Given this list of marker genes EBF1, SLAIN1, LRRTM3, ARHGEF26, ZNF254, UHRF2, ATP7B, DYRK1A, OSTC, SGIP1, ACKR4, GJC3, CBLL1, ETV3 (NCBI Gene Id 2117), ODR4, FPGT, FXR2, TBC1D23, CAMK4 (calcium/calmodulin dependent protein kinase IV), P2RY1, CHN2, PANK1, INVS, KLC1, MAGEB1, VIRMA, CCDC117, CHUK, VEGFD, AMMECR1, TMEM255A, CAMK2D, ARID4B, FGF5, EGFR, TUBGCP3 (tubulin gamma complex component 3), SGO1, MBNL2, ACVR2A, SYT4, POU2F2, OSBPL6, PDS5A, SLC25A13, BPTF, MAP3K2, CXorf66, CALCR, ANTXR2, MAGOH, HTRA3, TEAD3, USP15, ASXL3, MRI1, SNX9, RGS5, TMEM184A, MALT1, GARIN6, CREB5, FBN2, GOLGA1, DYNC1I1, MS4A3, CISD1 (CDGSH iron sulfur domain 1), PHF19, SPATA9, LY75, REST, USP38, STK17A, COL8A1, OTOGL, CPEB2, GANC, PALM2AKAP2, EMP2, MSR1, PTGER4, ZNF292, ACER3, FOXA2, AKAP7, CSTB, UNC79, PHF6, USP49, SP1, PLCH1, PTER, FSD2, RAB2A, NAALADL2, RIMBP2, KCNAB1, ZDHHC5, MLLT3, USP43, SNAPC5, CAPN2, CRTC1, SRGAP1, VPS45, NIPAL3, ZFP69B, SLC4A7, PPP4R3A, RICTOR, RSBN1L, PIP5K1B, LRRC8C, CERKL, ANKRD13C, ANK2, ANTXR1, COLEC12, APOBEC4, EHHADH, MGME1, BEGAIN, EID1, SCAI, EPCAM, SH2D1A, ITPR2, C11orf54, SORCS1, SCP2 (NCBI Gene Id 6342), SEMA6A, SHISA9, RNGTT, TMEM135, DPT, LRRTM2, SEC23IP, RASGRF2, MMUT, C20orf173, GYS2, NDUFV3 (NADH:ubiquinone oxidoreductase subunit V3), PRKACB, RPL36A, FNDC3A, TGFB2, KLF9 (NCBI Gene Id 687), KDM5A, SMC4, TMEM161B, GALNT15, SDHC, THSD7A, KIF13B, RNF207, PSMC2, IL5RA, RNF144A, ERBB4 (erb-b2 receptor tyrosine kinase 4), KCNK2, RTKN2, PCDH7, C6orf120, SFT2D3, INHBC, CUL4A, ZBTB6, TMEM248, ATF7IP (NCBI Gene Id 55729), GARRE1 (granule associated Rac and RHOG effector 1), ORC5, WNK2, XDH, DLG1, SYNPO2, TMEM39B, TSPO2, OGN, SMTNL1, PLEKHH1, BTG2, SYN2, CNTN6, PREX2, HIGD2A, MARVELD3 (MARVEL domain containing 3), EIF5, ARL4C, RNF19A, ATF1, FAM53C, SLC13A1, PRRG1, ZNF569, KLHL6, SPTA1, ZFHX3, ADARB2, ONECUT2, SEPHS1, MND1, SEC22C, TNFRSF8, UBA5, HYDIN, ZNF737, GREM2, ZNF267, AGAP1, RASAL2, CNOT7, CFTR, UQCRC1, BEND7, ZNF124, ZNF764, STAG2, RAB18, UBE2G1, NRXN1, GPR34, EPC2, BEND4, MAP3K20, TCN1, WDR77, SLC7A14, ZNF430, PICALM, SMIM21, THRSP, ZBTB24 (NCBI Gene Id 9841), RPL34, TNIK, LLCFC1, ZDHHC21, SKIC3, RANBP1, SLC16A7, CD1E, COG5, ITGA4, TRDMT1, CLOCK, TRHDE (NCBI Gene Id 29953), RALGDS, GTF2I, KIF19, BECN1, CCDC142, FAXC, DCX, ZRANB2, MSI2, RORA, TAFA5, EFNA5, MAZ, SOCS4, TTBK2, AADACL4, JARID2, CD164, HS3ST1, CBFA2T3, ZC3H15, here is a description of the gene set: from publication Chen Y, Wang X (PMID 31504780) Genes predicted to be targets of miRBase v22 microRNA hsa-miR-1290 in miRDB v6.0 with MirTarget v4 prediction scores > 80 (high confidence targets). Human Gene Set: MIR1290 studied in species Homo sapiens